The following is a description of a gene set: studied in species Mus musculus Mouse Gene Set: GOBP_SYNAPTIC_VESICLE_RECYCLING The trafficking of synaptic vesicles from the pre-synaptic membrane so the vesicle can dock and prime for another round of exocytosis and neurotransmitter release. Recycling occurs after synaptic vesicle exocytosis, and is necessary to replenish presynaptic vesicle pools, sustain transmitter release and preserve the structural integrity of the presynaptic membrane. Recycling can occur following transient fusion with the presynaptic membrane (kiss and run), or via endocytosis of presynaptic membrane., and this is the list of marker genes: Stx1b, Pclo, Bltp1, Synj1, Ap2m1, Park7, Git1, Abca13, Pacsin1, Cxadr, Nlgn1, Sh3gl2, Sgip1, Btbd9, Ap2s1, Scrib, Sncb, Itsn1, Dnajc6, Btbd8, Ap3s1, Ppp3cc, Dnm3, Sncg, Dennd1a, Cyfip1, Stx1a, Ap1s2, Pip5k1c, Dnm1l, Ap2a2, Tbc1d24, Ppp3cb, Rab5a, Vamp4, Syt7, Prkn (parkin RBR E3 ubiquitin protein ligase), Bin1, Git2, Cltb, Rab7, Diaph1, Fgf14, Ston2, Mx2, Capn2, Ap3s2, Ap2b1, Dnm2, Slc17a7, Scamp5, Pik3c3, Bcl2l1, Dgkq, Kcnc3, Arpc3, Picalm, Nlgn3, Fcho2, Arf6, Ophn1, Snx9, Lrrk2, Rab3a, Rac1, Actg1, Ston1, Ap3b2, Vamp2, Tor1a, Cltc, Actb, Rock1, Plaa, Rab27b, Ctbp1, Eps15l1, Cdk5, Otof, Syt11, Synj2, Slc2a4, Ap3d1, Dnm1, Snap91, Mff, Cd24a, Canx, Ap2a1, Snca, Grn, Itsn2, Gripap1, Amph, Myo5b, Sh3gl1, Ap3m2 (adaptor-related protein complex 3, mu 2 subunit), Atp8a1